The following is a description of a gene set: Enables the transport of a potassium ion across a membrane via a narrow pore channel that is open even in an unstimulated or 'resting' state. Human Gene Set: GOMF_POTASSIUM_ION_LEAK_CHANNEL_ACTIVITY studied in species Homo sapiens, and this is the list of marker genes: KCNK17, KCNK7, KCNK2, KCNK15, KCNK1, KCNK18, TMEM175, KCNK4, KCNK12, KCNK3, KCNK10, KCNK5, KCNK16, KCNK13, KCNK9, KCNK6